Given this list of marker genes Slit2, Lilrb4b, Trim27, Ppef2, Tsg101, Dnaja3, Mas1, Pid1, Pdcd4, Fabp4, Ager, Ier3, Nr2f2, Impact, Grb10, Slfn1, Rtraf, Cblc (NCBI Gene Id 80794), Prkg1, Cav1, Ptpn13, C9orf72, Dynll1, Tesk1, Hexim2, Tsc2, Spink1, Prkn, Dusp1, Errfi1, Gadd45b, Flcn, Myog, Gstp2, Cdkn1c, Cnksr3, Cda, Taf7, Rb1, Spred2, Prkrip1, Inpp5f, Parp1, Ppm1e, Chp1, Ttc36 (tetratricopeptide repeat domain 36), Tmed2, Cdkn1a, Tnf, Myocd, Sfrp1, Apoe, Dkk1, Ptgis, Epha1, Fbxo7, Mapk8ip1, Rgn, Git1, Ncor1, Zc3h12a, Ppargc1a, Hipk3, Ppp5c, Amdhd2, Mapt, Enpp1, Prdx3, Mir26a-1, Sirt1, Ppara, Ppp4c, Smyd3, Vps25, Abca2, Gpd1l, Nppa, Terf2ip, Slc8a3, Bag4, Ankle2, Cd300a, Pdgfa, Ajuba, Met, Ppp2ca, Sik2, Prkcz, Fkbp8, Nup62, Ctdspl, Cox11, Abl1, Dusp3, Slc8a1, Dtnbp1, Dusp6, Inpp5k, Ccnb1, Snca, Lats2 (NCBI Gene Id 50523), Tardbp, Smad7, Hyal2, Rgs2, Ntf3, 2610042L04Rik, Il2 (NCBI Gene Id 16183), Stk38, Sh2d1b1, Ibtk (NCBI Gene Id 71427), Ptk6, Tigar, Trib3, Xdh, Dusp7, Mir26b, Cav3, Gckr, Hspa4, Tgfb1, Gnaq, Bax, Aldob, Atxn7, Dusp19, Drd2, Akt1, Wars1, Cadm4, Pparg, Casp3, Prkch, Cep43, Tspo, Lyn, Park7, Hnf1a, Cep85, Il18, Kirrel2, Bak1, Ppp1r15a, Nprl2, Gpi1, Itgb1bp1, Ogt, Cactin, Ggnbp2, Niban1 (niban apoptosis regulator 1), Ppia, Lpcat1, Prkaca (NCBI Gene Id 18747), Ocln, Pibf1, Cd109, Grk2, Acp4, Hnf4a, Ceacam1, Rasip1, Psen1 (NCBI Gene Id 19164), Stap1, Socs3, Ptpro, Irs2, Gskip, Mtor, Slc27a1, Lrp6, Ctdsp1, Aida (NCBI Gene Id 72487), Zfyve28, Pkig, Fis1, Nck1, Dvl1, Cadm1, Shb, Zfp418, Spag9, Rabgef1, Gfra2, Akt1s1, Pten, Pip5kl1, Men1, Fbp1 (fructose bisphosphatase 1), Klhl31 (NCBI Gene Id 320711), Samsn1, Pfkfb1 (6-phosphofructo-2-kinase/fructose-2,6-biphosphatase 1), Hpn, Uri1, Trim63, Sirt6, Coro1c, Dgkq, Prkar1a, Adipoq, Lilrb4a, Tnfaip3, Kat2b, Tmem225, Cdkn2a, Gbp4, Pkn1, Sirt2, Dnajc3, Prkcd, Ptprt (protein tyrosine phosphatase receptor type T), Gstp1, Angpt1, Tmem132c, Spred1, Parp14, Tfap4, Qars1, Blvra, Hspb1, Gstp-ps, Ntrk3, Ppp1r15b, Wnk4, Spry1, Prr5l, Atp5if1, Suz12, Sh3bp5, Bdkrb1, Trib1, Gprc5a, Ctdsp2, Kirrel1, Spry4, Gadd45g, Eif4g1, Nolc1, Arrb1, Wee2, Pbk, Ptprh, Prkca, Inpp5j, Gadd45a, Cdk5rap3, Slc4a1, Iqgap1, Actn3, Plec, Hhex, Nupr1, Dbndd2, Irf1, Ppp2r5d, Mtch2, Mir26a-2, Ptpn6, Srcin1, Plek, Uchl1, Npm1, Smpd1, Ptpn1 (NCBI Gene Id 19246), Dnaja1, Prkdc, Garem1, Rassf2, Deptor, Nf1, Fbln1, Igf1, Mlxipl, Sfrp5, Trp53, Lats1, Cdk5rap1, Midn, Bdkrb2, Dnajc10, Pecam1, Mstn, Nnt, Cdkn2d, Rack1, Atxn1, Dab2ip, Insr, Agt, Apc, Il1b, Cib1, Lrrk1, Hnrnpu, Entpd1, Mllt1, Psen2, Macroh2a1, Rps23rg1, Pgk1, Prkag2, Ptprb, Sh3gl2 (NCBI Gene Id 319329), Traf3ip1, Ptprc, Pycard, Fem1a, Zbed3, Ptpn22, Heg1, Adarb1, Pard3, Cdkn2b, Epm2a, Hgf, Pkia, Smo, Rgs14, Myadm, Pard6a, Socs4, Dmtn, Irak3, Bag1, Jun, Mvp, Cbfa2t3, Zgpat, Wwtr1, Dusp22, Pax6, Gstp3, Ddit4, Nf2, Nlrp12, Ifng, Insm1, Bmp2, Stat3, Paqr3, Cdkn2c, Igfbp3, Adar, Chordc1, Ptprj, Gmppa, Gba1, Inca1, Socs1 (NCBI Gene Id 12703), Atg14, Socs5, Pdgfb, Apoc1, Spry2, Ptpn2, Ppm1f, Hdac4, Pebp1, Pkib (protein kinase inhibitor beta, cAMP dependent, testis specific), Hmgcr, Rd3, Ubash3b, Dusp10, Birc3, Plk1, Chmp6, Plpp3, Crkl, Cdkn1b, Thy1 (thymus cell antigen 1, theta), Sfrp2, Nron, here is a description of the gene set: studied in species Mus musculus Any process that decreases the frequency, rate or extent of the chemical reactions and pathways involving phosphorus or compounds containing phosphorus. Mouse Gene Set: GOBP_NEGATIVE_REGULATION_OF_PHOSPHORUS_METABOLIC_PROCESS